The following is a description of a gene set: A chromosome involved in sex determination. species: Mus musculus Mouse Gene Set: GOCC_SEX_CHROMOSOME, and this is the list of marker genes: Pcgf2, Smarcc1, Ube2a, Birc2, Smchd1, Rnf2, Hsf5, Suz12, Scml2, Macroh2a1, Smc6, Spdya, Daxx, Mael, Smarcb1, Sumo1, Hnrnpu, H2az1, Ring1, Eed, 1700013H16Rik, Dnmt3a, Rad18, Zcwpw1, Pcgf5, Usp7, Slx, Xist, Lrif1, Gm21064, Cdk2, Pbx4, Sin3b, Atr, H2ax, Ube2b (ubiquitin-conjugating enzyme E2B), Esco2, Dmrtc2, Plk4, Pcgf3, Brca1, H3f3a, Phc1, Smc5, Macroh2a2